Given this list of marker genes MTR, CLN3, OTC, SERINC5, GLUD2, SERINC3, HAO1, ASNS, PLOD2, PSAT1, PYCR1, MTHFD1, AGXT2 (NCBI Gene Id 64902), GOT1, PYCR2, APIP, PAH, NAGS, NOXRED1, AGXT, PYCR3, PSPH, MTRR, GLUD1, ASS1, GOT2, ASL, GLUL, PHGDH, SHMT2, GLS, ASNSD1, PLOD3, ALDH18A1, SHMT1, PCBD1, ADI1, GOT1L1, GLS2, LGSN, ENOPH1 (NCBI Gene Id 58478), OAT, BHMT, BHMT2, here is a description of the gene set: The chemical reactions and pathways resulting in the formation of any amino acid that is incorporated into protein naturally by ribosomal translation of mRNA, and that has a specific codon for translation from mRNA to protein. Human Gene Set: GOBP_PROTEINOGENIC_AMINO_ACID_BIOSYNTHETIC_PROCESS studied in species Homo sapiens